The following is a description of a gene set: species: Homo sapiens Pathway Definition from KEGG: Cholesterol -- (CYP7A1,CYP7B1,CYP39A1) >> HSD3B7 >> CYP8B1 >> AKR1D1 >> AKR1C4 >> CYP27A1 >> SLC27A5 >> AMACR >> ACOX2 >> HSD17B4 >> SCP2 >> ACOT8 -> Cholate Bile acid biosynthesis. Pathway ID: N00805. Pathway type: Reference. Pathway class: nt06022 Bile acid biosynthesis. Human Gene Set: KEGG_MEDICUS_REFERENCE_BILE_ACID_BIOSYNTHESIS, and this is the list of marker genes: AKR1D1, CYP7B1, CYP27A1, HSD17B4, CYP7A1, CYP39A1, SCP2, SLC27A5, ACOX2, ACOT8, CYP8B1, HSD3B7, AMACR, AKR1C4